Given this list of marker genes Kif4, Aurkb, Racgap1, Lzts2, Cdca8, Kif23 (kinesin family member 23, NCBI Gene Id 97568), Incenp, Ccdc69, Mlh1, Map10, Birc5, Prc1, here is a description of the gene set: The cell cycle process in which aggregation, arrangement and bonding together of a set of components to form the spindle midzone. The spindle midzone is the area in the center of the spindle where the spindle microtubules from opposite poles overlap. Mouse Gene Set: GOBP_SPINDLE_MIDZONE_ASSEMBLY species: Mus musculus